The following is a description of a gene set: Kennedy pathway from sphingolipids Human Gene Set: WP_KENNEDY_PATHWAY_FROM_SPHINGOLIPIDS studied in species Homo sapiens, and this is the list of marker genes: PTDSS1, SGPL1, PCYT2, ETNK2, PEMT, PCYT1A, PTDSS2, CHKA, PISD, ETNK1, CEPT1, PCYT1B (phosphate cytidylyltransferase 1B, choline), CHKB, CHPT1